Given this list of marker genes MIR128-1, GATA2, TRPV4, FLCN, SLC7A10 (NCBI Gene Id 83251), here is a description of the gene set: Any process that stops, prevents or reduces the frequency, rate or extent of brown fat cell differentiation. species: Homo sapiens Human Gene Set: GOBP_NEGATIVE_REGULATION_OF_BROWN_FAT_CELL_DIFFERENTIATION